Given this list of marker genes Chrm2, Lynx1, Chrm5, Chrng, Chrna2, Chrna1, Chrne, Chrnd, Ly6h (lymphocyte antigen 6 family member  H), Ly6a, Ly6c2, Chrm1, Chrna4, Chrna6, Tmem35a, Chrm3, Ly6c1, Cdk5, Slurp2, Lypd6b, Chrnb1, Ly6g6g, Chrna7 (NCBI Gene Id 11441), Ly6g2, Ly6g6d, Ly6i, Chrnb4, Pate4, Spdye4a, Lypd1, Spdye4b (speedy/RINGO cell cycle regulator family, member E4B), Anxa9, Chrna5, Psca, Ly6f, Lypd6, Ly6g, Chrnb3, Chrm4, Ly6m, Agrn, Ly6g6e (NCBI Gene Id 70274), Chrnb2, Chrna3, Slurp1, Ly6e, here is a description of the gene set: Combining with an acetylcholine receptor ligand and transmitting the signal from one side of the membrane to the other to initiate a change in cell activity. Mouse Gene Set: GOMF_ACETYLCHOLINE_RECEPTOR_ACTIVITY studied in species Mus musculus